Given this list of marker genes Yrdc, Trp53rkb, Ctag2l1, Cdk5rap1, Ctag2, Osgepl1, Trmt5, Trp53rka, Trit1, Ctag2l2, Lage3, Mto1, Trmt10c, Osgep, Rpusd4, Tprkb, Hsd17b10, Gon7, Mettl8, here is a description of the gene set: Mouse Gene Set: GOBP_TRNA_THREONYLCARBAMOYLADENOSINE_METABOLIC_PROCESS The chemical reactions and pathways involving tRNA threonylcarbamoyladenosine, a modified nucleoside found in some tRNA molecules. species: Mus musculus